The following is a description of a gene set: Marker genes curated from the annotated cluster as represented in the Descartes Human Gene Expression During Development database. studied in species Homo sapiens from publication Cao J, O'Day DR, Pliner HA, Kingsley PD, Deng M, Daza RM, Zager MA, Aldinger KA, Blecher-Gonen R, Zhang F, Spielmann M, Palis J, Doherty D, Steemers FJ, Glass IA, Trapnell C, Shendure J (PMID 33184181) The gene expression program underlying the specification of human cell types is of fundamental interest. The study authors generated human cell atlases of gene expression and chromatin accessibility in fetal tissues. For gene expression, the study authors applied three-level combinatorial indexing to >110 samples representing 15 organs, ultimately profiling ~4 million single cells. The study authors leveraged the literature and other atlases to identify and annotate hundreds of cell types and subtypes, both within and across tissues. Our analyses focused on organ-specific specializations of broadly distributed cell types (such as blood, endothelial, and epithelial), sites of fetal erythropoiesis (which notably included the adrenal gland), and integration with mouse developmental atlases (such as conserved specification of blood cells). These data represent a rich resource for the exploration of in vivo human gene expression in diverse tissues and cell types. Human Gene Set: DESCARTES_MAIN_FETAL_ENDOCARDIAL_CELLS, and this is the list of marker genes: THBS3, IL33, NAB1, NORAD, SMAD6, BMX, NPPC, RAMP2, APCDD1L, FBLN2, HRCT1, TNFAIP1, TPT1P15, F2RL2, TMEM100, SLC6A4, EMCN, PROCR, BAALC-AS1, RHOA (ras homolog family member A), MANSC1, PRCP, THBD, PTHLH, PWWP3B, TLNRD1, NT5E, NUCB1, GJA4, CALHM5, CLEC3B, SLC35A1, DKK2, CPXM2, NBL1, CCL26, FMOD, POSTN, NPR1, ACKR4, ZBTB8A, ECSCR, LTC4S, AGPS (alkylglycerone phosphate synthase), FZD4, LEPR, CALCRL, TNFSF12, GINM1, FOXC1, MMRN2, FUT11, LRIG3, CDH11, INPP1, HYAL2, CALR, F8, CGNL1, HEG1, ENSG00000255462, SMCO3, CTHRC1, FZD6, AVPR2, CLIC2, ITGA10, SPARCL1, ARMCX2, NPDC1, MCHR1, CD99, CPD, HS3ST1, ELK4, SMAD7, HMCN1, ACKR3, HAPLN1, ECE1, ENG